Given this list of marker genes SAMD4B, DDX39A, USP7, KLF12, CPSF6, APLP2, MACF1, ZDHHC9, TENT5C, BCL9L, AGO1, GPM6A, RASL12, TSHZ3 (teashirt zinc finger homeobox 3), ZIC3, ADAM10, ARID4B, ACVR2A, SCAMP1, SRSF2, KIF1B, PURG, DYRK1A, ZIC1, CAMK2G, TRPS1, MKRN1, KMT5B, UBE2L3, SRSF8, GNG12, STAG2, TRIM9, here is a description of the gene set: Genes having at least one occurence of the motif GGTAACC in their 3' untranslated region. The motif represents putative target (that is, seed match) of human mature miRNA hsa-miR-409-5p (v7.1 miRBase). Human Gene Set: GGTAACC_MIR4095P species: Homo sapiens